The following is a description of a gene set: part of: Conjugation of carboxylic acids Reactome Pathway: Conjugation of salicylate with glycine species: Mus musculus This event has been computationally inferred from an event that has been demonstrated in another species.<p>The inference is based on the homology mapping from PANTHER. Briefly, reactions for which all involved PhysicalEntities (in input, output and catalyst) have a mapped orthologue/paralogue (for complexes at least 75% of components must have a mapping) are inferred to the other species. electronically inferred by orthology from the curated human pathway, and this is the list of marker genes: Acsm4, Acsm2, Glyatl3 (NCBI Gene Id 435528), Acsm5